The following is a description of a gene set: Mouse Gene Set: GOBP_RESPONSE_TO_CHEMOKINE Any process that results in a change in state or activity of a cell or an organism (in terms of movement, secretion, enzyme production, gene expression, etc.) as a result of a chemokine stimulus. species: Mus musculus, and this is the list of marker genes: Ccl5, Hif1a, Robo1, Wbp1l, Ccl24, Ccrl2 (NCBI Gene Id 73654), Cxcr3, Ccr9, Tff2, Dock8, Xcr1, Ccl4, Ccr3, Jak2, Ccl19, Slc12a2, Reg1, Ccl2, Entrep1, Mpl, Ccl12, Rbm15, Slit2, Ccr4, Ccl25, Rhoa, Ccl22, Cxcr6, Ccl9, Cxcl13, Ackr1, Muc19 (NCBI Gene Id 667734), Cib1, Gpr75 (G protein-coupled receptor 75), Zc3h12a, Edn1, Cxcl12, Ccl8, Ccr6, Ripor1 (NCBI Gene Id 75687), Ccr2, Slit3, Oxsr1, Stk39, Ccr5, Ackr4, Ccr7, Ccl1, Sh2b3, Wnk1, Thpo, Ccl7, Ccr1l1, Rnf113a2, Cxcl9, Ccl21a, Lrch1, Cx3cr1, Xcl1, Cxcr2, Cxcr5, Cxcr1, Padi2, Ackr2, Ccl6, Dusp1 (dual specificity phosphatase 1), Ackr3, Gpr35, Ccl26, Foxc1, Lox, Cxcl17, Ccr1, Ccr10, Cx3cl1, Cxcl10, Ccl3, Ptk2b, Rnf113a1, Grk2, Ripor2, Cxcr4, Lyn, Cxcl11, Trem2 (NCBI Gene Id 83433), Ccl21b, Ccl11, Ccr8